Given this list of marker genes PLS3, CXCR4, PDE4DIP, GAD1, LHX6, MAF, ERBB4, RBP1, PDZRN4, NXPH1, here is a description of the gene set: from publication Fan X, Dong J, Zhong S, Wei Y, Wu Q, Yan L, Yong J, Sun L, Wang X, Zhao Y, Wang W, Yan J, Wang X, Qiao J, Tang F (PMID 29867213) Human Gene Set: FAN_EMBRYONIC_CTX_IN_4_INTERNEURON species: Homo sapiens